Given this list of marker genes Tubb6, Tuba1b, Tubb2b, Tuba4a, Dync1li2, Tubb4b, Tuba8 (NCBI Gene Id 53857), Tuba1a, Dctn6, Fkbp4, Tuba1c, Dynll1, Dctn1, Nr3c1, Actr10 (NCBI Gene Id 56444), Tubal3, Tuba3b, Hspa1l, Dnajb1, Hspa2, Tubb4a, Ar, Actr1a, here is a description of the gene set: species: Mus musculus This event has been computationally inferred from an event that has been demonstrated in another species.<p>The inference is based on the homology mapping from PANTHER. Briefly, reactions for which all involved PhysicalEntities (in input, output and catalyst) have a mapped orthologue/paralogue (for complexes at least 75% of components must have a mapping) are inferred to the other species. part of: Cellular responses to stress electronically inferred by orthology from the curated human pathway Reactome Pathway: HSP90 chaperone cycle for steroid hormone receptors (SHR) in the presence of ligand